The following is a description of a gene set: studied in species Homo sapiens Human Gene Set: GOBP_CELL_PROLIFERATION_INVOLVED_IN_METANEPHROS_DEVELOPMENT The multiplication or reproduction of cells, resulting in the expansion of the population in the metanephros., and this is the list of marker genes: GPC3, SHH, EGR1, PTCH1, STAT1, BMP7, OSR1, MYC, WT1, PDGFRB